The following is a description of a gene set: from publication Chen Y, Wang X (PMID 31504780) Mouse Gene Set: MIR_3961 Genes predicted to be targets of miRBase v22 microRNA mmu_miR_3961 in miRDB v6.0 with MirTarget v4 prediction scores > 80 (high confidence targets). species: Mus musculus, and this is the list of marker genes: Lrp6, Slc17a7, Cfl2, Tmc3, Ube2w, Zc3h7b, Npsr1, Pou2f2, Slc25a38, Nudt18, Ganab, Gid4, Fbxl20, Pou2f1, Mamdc4, Ppp1r9b, Prpf40a, Nol4, Map1b, Jrk, Teddm1b (NCBI Gene Id 433365), Ccdc15, Orc2, Ank2, Ubfd1, Aptx, Kif16b, Arid3a, Neurl1a, Scn1a, Psd3, Sh3pxd2a, Peak1, Parvb, Vps37d, Pigm, Sart3, Adgrg2, Myf5, Klf6, Sstr5, Axin2, Gys1, Pik3r3, Prox2, Tchp, Prr18, Ugcg, Pank3, Akr1b8, Fbxw7, Mef2c, Rpgrip1, Casp2, Necap1, Lamc1